Given this list of marker genes PAICS, NDOR1, KIF23, PKNOX1, TAF1C, FBRS, LAT, SPATA2L, FAM78A, EIF1AD, SYNRG, JADE2, SASH3, LETM1, PADI3, ZBTB45, CWC25, CPA3, IMPA2, RNPS1, TTI1, TCOF1, CCR9, METTL2B, PSMD8, ACAA2, PSD4, TRIM56, LRRC28, RGS14, COPS4, RBM19, FRAT2, ZBTB25, MAST3, LYRM9, BARD1, VPS26B, RASGRP1, RPF1, RAE1, PAG1, RPS6KB2, PRKD3, AP4E1 (NCBI Gene Id 23431), INPP5E, CWF19L1, BAG5 (NCBI Gene Id 9529), CACNA2D4, RHOH, TP53I13, RABGGTA, TRMT12, DZIP1, MED29, MRPL35, TMLHE, ELMO1, GATD1, ANGPTL1, CD3D, GNB1L, MTA3 (metastasis associated 1 family member 3), CCDC125, RAI1, DYNC1LI1, C2orf68, IL16, SMUG1, E2F1, TRAPPC12, TBXA2R, ORAI2, OTUD5, MYBL1, SLX4, EIF4A3, GPS2, PTP4A3, FBXO9, TTC19 (tetratricopeptide repeat domain 19), PIP4K2A (phosphatidylinositol-5-phosphate 4-kinase type 2 alpha), RNF126, LSM2, HCFC1, ZBTB2, DCP1B, SH3GLB2 (NCBI Gene Id 56904), EIPR1, LYAR, MED12, TYSND1, CD247 (CD247 molecule), RAD52, DNM2, PLCXD2, TXNIP, APOOL, CYFIP2, ABL1, MRPS26, EXOSC10, PITPNA, CAND2, STK11, KYAT1, ATPAF1, GATAD1, ABCB8, PCNX3, CEP57L1, DERA, SKAP1, KLC3, SATB1, UBE2D3, RAB35, HIKESHI, ZAP70, TXNDC11, DEF6, ABCB7, TIMM22, ACD, SART3, MEF2D, TAF5L, ZNF408, TAF1D, DNAJC5, RPA1, NR1H2, CDCA4, DDX23, PRKAB1 (protein kinase AMP-activated non-catalytic subunit beta 1), RNF5, PIAS2, RUFY2, LTA4H, SMC1A, BTF3L4, CHAF1B, TACC1, FANCF, DHODH, MAP4K1, TCF7, PMS2, PRMT5, CBX2, RAD18, SIT1, GABPB2, PBX4, IMPDH1, SNAI3, OLA1, STRN4, OXA1L, ABHD8, CDC40, PYCARD, CDT1, NUP188, PHF23, TBX6, ZCCHC9, RAD9A, IPP, CTNNBL1, ITGA4, EHMT1, NSG2, ZMPSTE24, NOL11, NADSYN1, DNAJB1, MED27, SH2B1, SNX15, NSUN5, ZNRF1, ICAM2, WRAP73, TJAP1, MAPK7, XPO4, KLHL6, TEX261, NRM, GGCX, TBC1D10C (NCBI Gene Id 374403), KARS1, CRTC3, WDR24, POLE2, PXMP4, EPHB6, TLE5, here is a description of the gene set: from publication Borjesson DL, Kobayashi SD, Whitney AR, Voyich JM, Argue CM, Deleo FR (PMID 15879137) species: Homo sapiens Genes down-regulated in polymorphonuclear leukocytes (1.5h): control versus infection by A. phagocytophilum. Human Gene Set: GSE2405_0H_VS_1.5H_A_PHAGOCYTOPHILUM_STIM_NEUTROPHIL_DN Polymorphonuclear leukocytes (PMNs) were obtained from healthy individuals in accordance with protocols approved by the Institutional Review Board for Human Subjects at the University of Minnesota and the National Institute of Allergy and Infectious Diseases. PMNs (107) were combined on ice with live S. aureus (108) or with live or heat-killed A. phagocytophilum (bacteria isolated from 5x106 infected HL60 cells for a ratio of 1 infected HL60 cell: 2 PMNs, ~ 5-20 A. phagocytophilum: PMN) in wells of a 12-well tissue culture plate (pre-coated with 20% autologous normal human serum). Unstimulated control assays received either buffer (for S. aureus comparisons) or clarified HL60 lysate (for A. phagocytophilum comparisons). Plates were centrifuged at 350 x g for 8 min at 4oC to synchronize phagocytosis and incubated at 37 deg. C in a CO2 incubator for the indicated times. At the indicated times, tissue culture medium was aspirated from the plate and PMNs were lysed directly with RLT buffer (Qiagen, Valencia, CA). Purification of PMN RNA and subsequent preparation of labeled cRNA target was performed as described in Methods. Labeling of samples, hybridization of cRNA with HU133A oligonucleotide arrays (Affymetrix, Santa Clara, CA), and scanning were performed according to standard Affymetrix protocols ( http://www.affymetrix.com/pdf/expression_manual.pdf ). Experiments were performed in triplicate, using PMNs from three healthy individuals for each treatment.